Given this list of marker genes Snx3, Mier2, Klrb1b, Sik3, Klrb1c, Ncaph2 (NCBI Gene Id 72506), Map7d1, here is a description of the gene set: species: Mus musculus Genes predicted to be targets of miRBase v22 microRNA mmu_miR_675_5p in miRDB v6.0 with MirTarget v4 prediction scores > 80 (high confidence targets). from publication Chen Y, Wang X (PMID 31504780) Mouse Gene Set: MIR_675_5P